The following is a description of a gene set: Genes negatively correlated with HAI response at 28d in peripheral blood mononuclear cell in adults (18-50) after exposure to Fluarix/Fluvirin, time point 3D. Comment: Supplementary Table 5: All genes whose expression (d3/d0 or d7/d0) correlates to the fold increase in HAI titers (d28/d0). Here we have used a systems biology approach to study innate and adaptive responses to vaccination against influenza in humans during three consecutive influenza seasons. We studied healthy adults vaccinated with trivalent inactivated influenza vaccine (TIV) or live attenuated influenza vaccine (LAIV). TIV induced higher antibody titers and more plasmablasts than LAIV did. In subjects vaccinated with TIV, early molecular signatures correlated with and could be used to accurately predict later antibody titers in two independent trials. Notably, expression of the kinase CaMKIV at day 3 was inversely correlated with later antibody titers. Vaccination of CaMKIV-deficient mice with TIV induced enhanced antigen-specific antibody titers, which demonstrated an unappreciated role for CaMKIV in the regulation of antibody responses. Thus, systems approaches can be used to predict immunogenicity and provide new mechanistic insights about vaccines. Human Gene Set: NAKAYA_PBMC_FLUARIX_FLUVIRIN_AGE_18_50YO_CORRELATED_WITH_HAI_28DY_RESPONSE_AT_3DY_NEGATIVE studied in species Homo sapiens from publication Nakaya HI, Wrammert J, Lee EK, Racioppi L, Marie-Kunze S, Haining WN, Means AR, Kasturi SP, Khan N, Li GM, McCausland M, Kanchan V, Kokko KE, Li S, Elbein R, Mehta AK, Aderem A, Subbarao K, Ahmed R, Pulendran B (PMID 21743478), and this is the list of marker genes: RORA, SLC38A1, USP16, MAP3K4, NOL7, SMN2, GPAM, SYNCRIP, FOXO1, SEPTIN2, CNST, ZC3H11A, RSRC2, ATRX, RBM25, KRR1, WASF2, LY9, FAM20B, EBLN2, N4BP2, EPB42, GOLGA8A, SGTB, SNCA, TMEM243, FAM133B, RYK, NKTR, LCOR, ZNF26, SRSF11, PTPN2, MED21, PPIG, ZNF131, DHX36, AFF4, ZNF136, CHORDC1, ZNF331, NUCB2, FNBP4, BCL11B, SEPSECS, ZBTB25, MPHOSPH8, ELP2, SCML1, TOMM20, TNIK, BEX2, AHCTF1, FAM98B, DNAJC2, RHOH, KLF12, TC2N, TENT4B, LUC7L2, APBA2, NEDD1, CIR1, ITPR1, PPM1A, ITM2A, UTP4, STMN3, GPR183, SRSF6, DLST, DNAJB1, AFF3, IL6ST, RBM39, TRAT1, RUNX3, PTCD3, FAM76B, CTC1, NAP1L5 (nucleosome assembly protein 1 like 5, NCBI Gene Id 266812), IVNS1ABP, KDM6A, SYNE2, TNKS, CETN2, NGDN, PDE4DIP, NAE1, NUCKS1, MATR3, SAR1A, TAF4B, TMEM263, CDK12, PIK3IP1, HNRNPD, DUSP11, CNOT6L (CCR4-NOT transcription complex subunit 6 like), SFPQ, SFXN1, CEP57, CD28, RSBN1, HGD, GON4L, ENDOD1, DDX47, FHL1, ZNF814, CREBRF, NOL11, C12orf75, PPP4R3A (NCBI Gene Id 84644), CDR2, EZR, DBF4, TRMT13, PRRC2C, PIK3R1, CD3G, RAB30, LINC02076, NR1D2, GNB5, RNF138, DANCR, KDM7A, GNAS, CDC42SE2, PLA2G12A (phospholipase A2 group XIIA), ITGA6, GAS5, CAMK4, ZFR, CTLA4, TUBB1, CHD1, KCNA3, ZNF512B, FAM153A, ATF7IP2, GKAP1, OXNAD1, C11orf58, SLC25A36, RAPGEF6, NDFIP2, SF1, TWF1, PPFIBP1, PNISR, FBXL3, ZMYM2, ARMH1, SINHCAF, SH2D1A, MAN1C1, MSI2, USPL1, SETD2, GGTA1, URI1, STK17A, WTAP, BRD1, DENND11, BANK1, FAM169A, BCLAF1, GPRASP1, JAK1, MALAT1, SVIP, ADTRP, ZCCHC10, RNMT, TTC3, MED23, PRKRA, ZNF101, EAPP, COX11, TM9SF3 (transmembrane 9 superfamily member 3), TNPO1, AK3, ZNF292, ZEB1, CCDC50, USP12, OCIAD2, KIAA1143, METAP2, PRKACB, MAML2, SOS2 (SOS Ras/Rho guanine nucleotide exchange factor 2), CCND2, NOSIP, ARL4C, GNE, MGAT4A, ATG13, CD3D, FAM162A, SNRPN, LSG1, HEATR1, PRORP, ESCO1, BOLA2, RPL37, B3GNT7, ZNF274, DNAJB14, KPNA5, EML4, ITPKB, PNN, CEBPZ, SMC3, TENT5C, EPB41L4A-AS1, P2RY10, ECD, SRSF3, SMIM19, FOXP1, GOLGA8B, ZNF92, DIS3, WDR89, SPTY2D1, DCAF16, TSPYL1, SNHG8, TBC1D15, TPP2, TIPARP, TRAC (NCBI Gene Id 28755), ADPRM, CFAP36, ATOSA, RBM38, TGFBR2, DDHD1 (DDHD domain containing 1), KLRB1, LMO7, H1-3, POLR2M, ARHGAP24, USP36, ITK, ZNF395, JMY, DUSP4, METTL8, STK4, DNTTIP2, SSBP1, VIRMA, PRKCQ, PHF20L1, C12orf57, PPP1R2, KLHL24, CBLB, ISCA1, ANK3, PPP1R16B, PHF5A, RC3H2, POLR3E, CCNT1, PPP1CB, SLC16A7, NUFIP1, DDX11L2, LEF1, KPNA3, ZNF12, TAF9B, ATP2B1, CLK4, THOC2, THEMIS, STAT4, PIK3CA, ZNF22, RLIG1, SNHG1, HBP1, TTC32, SH3YL1, BBX, TMEM220, ANKRD36, H2AZ2, RALGAPA1, STT3B, CDC14B, CDK17, AQP3, PASK, SMN1, YTHDC1, ZNF277, RCAN3, CEPT1, AMD1, SBDS, ITGB3BP, RGCC, SNRK, PSPC1, SLC4A7, BEX4 (brain expressed X-linked 4), PURB, TRAPPC10 (NCBI Gene Id 7109), CBX5, GGNBP2, KLF9, CLASP1, GCOM1, EWSR1, CEP95, CAVIN2, PTPN4, PTS, PCBP2, KDM3A, HSF2, MFSD14A (NCBI Gene Id 64645), RICTOR, MEX3C, TRIM13, SECISBP2L, BACH2 (NCBI Gene Id 653980), TUBB6, MED30, TMEM106B, JUND, RSL24D1, ATXN7, KAT6B, RGPD5, FUS, ANKRD12, SUPV3L1, BPGM, PDE4D, METTL16, MTF2, RANBP2, NAA25, UFL1, ZBTB38, HMGB1, CHD2, CLDND1, CWF19L2, MLH3, USP47, CHIC1